The following is a description of a gene set: Human Gene Set: chr7p13 species: Homo sapiens, and this is the list of marker genes: LINC00957, ENSG00000297670, RASA4EP, RNA5SP230, TMED4, YKT6, SNORA5B, TUBG1P, RPL32P18, DBNL, MIR4657, POLM, GCK, MYL7, CCM2, BLVRA, NACAD, ENSG00000303071, TBRG4, RAMP3, SNORA9, SPDYE1, ELK1P1, COA1, LUARIS (lncRNA upregulator of antiviral response interferon signaling), MYO1G, NPC1L1, ZMIZ2, SNHG15, SNORA5C, UBE2D4, RNU6-1097P, POLR2J4, MIR6838, CAMK2B, MIR6837, PURB, H2AZ2-DT, PGAM2, H2AZ2, URGCP-MRPS24, URGCP, RASA4CP, UPK3BL3P, POLD2, AEBP1, MRPS24, ENSG00000307930, SNORA5A, PPIA, RPL36AP27 (ribosomal protein L36a pseudogene 27), ENSG00000297379, STK17A, DDX56, NUDCD3, MIR4649, OGDH